The following is a description of a gene set: Genes down-regulated in CD4+ T lymphocytes transduced with FOXP3. Mouse Gene Set: ONO_FOXP3_TARGETS_DN species: Mus musculus Naturally arising CD25+CD4+ regulatory T cells (T(R) cells) are engaged in the maintenance of immunological self-tolerance and immune homeostasis by suppressing aberrant or excessive immune responses, such as autoimmune disease and allergy. T(R) cells specifically express the transcription factor Foxp3, a key regulator of T(R)-cell development and function. Ectopic expression of Foxp3 in conventional T cells is indeed sufficient to confer suppressive activity, repress the production of cytokines such as interleukin-2 (IL-2) and interferon-gamma (IFN-gamma), and upregulate T(R)-cell-associated molecules such as CD25, cytotoxic T-lymphocyte-associated antigen-4, and glucocorticoid-induced TNF-receptor-family-related protein. However, the method by which Foxp3 controls these molecular events has yet to be explained. Here we show that the transcription factor AML1 (acute myeloid leukaemia 1)/Runx1 (Runt-related transcription factor 1), which is crucially required for normal haematopoiesis including thymic T-cell development, activates IL-2 and IFN-gamma gene expression in conventional CD4+ T cells through binding to their respective promoters. In natural T(R) cells, Foxp3 interacts physically with AML1. Several lines of evidence support a model in which the interaction suppresses IL-2 and IFN-gamma production, upregulates T(R)-cell-associated molecules, and exerts suppressive activity. This transcriptional control of T(R)-cell function by an interaction between Foxp3 and AML1 can be exploited to control physiological and pathological T-cell-mediated immune responses. from publication Ono M, Yaguchi H, Ohkura N, Kitabayashi I, Nagamura Y, Nomura T, Miyachi Y, Tsukada T, Sakaguchi S (PMID 17377532), and this is the list of marker genes: Il21, Fasl (NCBI Gene Id 14103, Fas ligand), Casp1, Cxcr4, Havcr2, Sell, Parp1, Eomes, Il17ra, Igfbp4, Bcl2, Ccna2, Runx3, Rbl2, Runx2, Tnfsf8, Ccnf, Tnfrsf25, Sgo1, Il17a, Cdkn1a, Casp4, Cxcr6, Il4, Il4ra, Cd84, E2f1, Sema4a, Rbl1, Slfn1, P2ry14, Ccl5, Slamf6, Gzma (NCBI Gene Id 14938), Foxn3, Hnrnpa1, Ctla2b, Slfn2, Irf4, Ffar2, Tcf3, Tgfbr3, Gpr171, Cdk6